Given this list of marker genes 1810007D17Rik, Sycn, Tle5, Jund, Mpo, here is a description of the gene set: Mouse Gene Set: TABULA_MURIS_SENIS_PANCREAS_PANCREATIC_ACINAR_CELL_AGEING species: Mus musculus from publication Tabula Muris Consortium (PMID 32669714)